The following is a description of a gene set: studied in species Homo sapiens Genes in the cancer module 356. Human Gene Set: MODULE_356, and this is the list of marker genes: DLK1, FADS1, RNF4, PPP2R5C, PFDN4, DBNDD1, CLIC4, GATM, LEAP2, ATG5, WWP1, ME2, TNFRSF14, H4C14, NF2, CBY1, ROPN1, MKNK2, EPS15L1, SLC25A37, LYN, LIMCH1, GATAD2A, ELL, DCTPP1, ELMO2, SMYD5, TRAF6, R3HDM1, MARF1, MTMR2 (NCBI Gene Id 8898), SLC25A16, MARCKS (NCBI Gene Id 4082), BMP2, FKBP1B, PLPBP, IL1R1, JAG1, SEPHS1, TSPAN18, RNASEH2C, CCDC88A, VASH2, CTNNAL1, SMC1A, THOP1, GPER1 (NCBI Gene Id 2852), RPL10, RXRB, THY1, IFT88, SSR3, TMEM97, ZNF217, PCGF3, GJA5, PTBP1, TGFB1, AVL9, PIF1 (PIF1 5'-to-3' DNA helicase), LAMTOR1, AUP1, KLK6, CD14, CRNKL1, MECP2, MYO1C, PRSS3, EXOSC4, ZNF423, SLC25A1, ENAH, RHAG, PICALM, NNT, RABIF, GC, CC2D2A, OXR1, NINJ1, PRDM1, LSM14A, CD40, PON3, MPPE1, MGAT3, SZT2, WWTR1, ELK1, TBC1D2B, EFTUD2, CHRNA1, SETDB1, ALG12, FOXS1, TIE1, CCN3, RPLP2, GABRA2, PTGER3, MAPK4, PSMD2, PLAUR, TRAM1, PPP2R5D, NUP54, NXN, ACACB, ACTA1, TECPR2, CDC42SE2, SREBF1 (sterol regulatory element binding transcription factor 1), GNAI1, CHORDC1, MAPT, ZNF667, TRMT11, KPTN, SARM1, NCK1, ITGA8, DHODH, NPRL3, PPP4R1, MYLK2, POFUT1, PLAGL2, PTMA, TAGLN3, TYMP, CKB (NCBI Gene Id 96634), WNT5B, EID1, H3-3B (H3.3 histone B), SRP14, LIMS3, PNLIP, TXNDC16, GLRX (NCBI Gene Id 90885), RNF11, HYOU1, PHRF1, ADA, SLC20A1, DLL1, KLHDC10, HOXC4, KLF1, TRIM4, SLC9A1